Given this list of marker genes Trip10 (NCBI Gene Id 106628), Edn1, Fdps, Ep300, Akap6, Igf1, Mtor, Slc25a4, Ddx39b, Hamp, Sirt1, Pin1, Hamp2, Pin1rt1, Nr3c1, Adrb1, Ccn4, Parp2, here is a description of the gene set: studied in species Mus musculus Mouse Gene Set: GOBP_POSITIVE_REGULATION_OF_CELL_GROWTH_INVOLVED_IN_CARDIAC_MUSCLE_CELL_DEVELOPMENT Any process that increases the rate, frequency, or extent of the growth of a cardiac muscle cell, where growth contributes to the progression of the cell over time from its initial formation to its mature state.